The following is a description of a gene set: The presence of autoantibodies in the serum that react against proteins predominantly expressed in perinuclear region of neutrophils. Perinuclear antineutrophil antibody positivity studied in species Homo sapiens Human Gene Set: HP_PERINUCLEAR_ANTINEUTROPHIL_ANTIBODY_POSITIVITY, and this is the list of marker genes: CTNNB1, SERPINA1, DEF6, PTPN22, CTLA4, BACH2, ARPC1B, PRTN3, HLA-DPB1, DNASE1L3, HLA-DPA1